Given this list of marker genes ATG101, FTCD, QKI (QKI, KH domain containing RNA binding), CES1, TRIO, DCAKD, MUC13, MMS19, OXCT1, FGF5, B2M (beta-2-microglobulin), GPR17, RAB29, CTNNA2, GNPTAB, PSMB8, APEH, CRIP3, PSME1, IFIT2, TRIM68, HTATIP2, KRTAP4-11, EMC3 (ER membrane protein complex subunit 3), RANBP9, E2F7, TMEM268, FYB1, LIPA, CNN3, LAMP2, RAI2, KCTD18 (potassium channel tetramerization domain containing 18), MINAR1, CAP1, ZDHHC6, CSTF2T, TMEM217, CHADL, RDH14 (NCBI Gene Id 57665), ITM2B, LRRC72, SPX, GDAP1, KLHL41, ZFAND3, ARID3B, CHRNA1, TRAF2 (NCBI Gene Id 7186), KAZALD1, VPS4B (NCBI Gene Id 9525), RBKS, TXLNA, KNSTRN, LARP6, MINAR2, C2CD4C, LPIN2, EBPL, G6PD, CD300LG, NPAT, CIB1, SP110, CENPU, IL9R, CLASP1, RND1, STRC, SUSD6, HLA-G, CPD, ZNF335, MED8, YIPF1, FUNDC1, MPI, TWF1, WASHC2A, GNG2, PARD6G, LDHC, GTF3C5, RFXANK, DNAJC5, SLC2A1, GSDMD, DYDC2, USF1, DIAPH3, MED29, NID1, SUCO, MYT1L, SYCP2L, CCDC77, GPCPD1, MCUB, SYNE2, PPHLN1, PGD, PLA2G15, URGCP, SBDS, CFHR2, KDM5C, FAM83D, ODAD3, MAST2, GABRG1, PHRF1, TAOK1, ATOSA, CYB5R3, COL4A5, HMGCS1, CD247, SFRP1, IPO8, TRAM2, DENND10, ARHGEF3, SNAI3-AS1 (SNAI3 antisense RNA 1), TRAM1L1, NCAPG, CAP2, TMEM140, KIF20A, IFNAR2, ASCL1, NAA50, ATG3, ADAM9, MSX2, FBXO24, PTPRR (NCBI Gene Id 5801), NTN5, NDC80, GSTT1, CDK5RAP3, LEO1, GNG8, GDPGP1, CDCA3, SLC30A9, SOCS7, MFN1, SLC9A9, PON3, NDUFS3, OSMR, GTF3C2, SLAMF1, MBOAT2, SHCBP1, MAT2A, ERBB4, CLASRP, RUNDC1 (RUN domain containing 1), MTUS1, KIF18B, RIOK1, BRCA2, PSMD4, MFSD8, TMEM181 (NCBI Gene Id 57583), ALPK3, HTR3B, TMEM87A, DCUN1D2, COG3, CYB5R2, SLC35F3, SULT4A1, FANCD2, ARL15, KPNA7, SYT3, NPY2R, PUS7L, CARS2, TINF2, CHD1L, ECI2, GGH, CASP6, SPAG9, PSME4, EPRS1 (NCBI Gene Id 2058), PPP3CC, VAPB, KNL1, OPA1, PTP4A2, DNAJB13, PRR11, KBTBD2, BLMH, VIPAS39, MAPK7, here is a description of the gene set: Borrelia burgdorferi, the agent of Lyme disease, promotes pro-inflammatory changes in endothelium that lead to the recruitment of leukocytes. The host immune response to infection results in increased levels of IFN-gamma in the serum and lesions of Lyme disease patients that correlate with greater severity of disease. Therefore, the effect of IFN-gamma on the gene expression profile of primary human endothelial cells exposed to B. burgdorferi was determined. B. burgdorferi and IFN-gamma synergistically augmented the expression of genes, seven of which encode chemokines. Six of these (CCL7, CCL8, CX3CL1, CXCL9, CXCL10, and CXCL11) attract T lymphocytes, and one (CXCL2) is specific for neutrophils. Synergistic production of the attractants for T cells was confirmed at the protein level. IL-1beta, TNF-alpha, and LPS also cooperated with IFN-gamma to induce synergistic production of CXCL10 by endothelium, indicating that IFN-gamma potentiates inflammation in concert with a variety of mediators. An in vitro model of the blood vessel wall revealed that an increased number of human T lymphocytes traversed endothelium exposed to B. burgdorferi and IFN-gamma, as compared to unstimulated endothelial monolayers. In contrast, addition of IFN-gamma diminished the migration of neutrophils across B. burgdorferi-activated endothelium. IFN-gamma thus alters gene expression by endothelium exposed to B. burgdorferi in a manner that promotes recruitment of T cells and suppresses that of neutrophils. This modulation may facilitate the development of chronic inflammatory lesions in Lyme disease. from publication Dame TM, Orenzoff BL, Palmer LE, Furie MB (PMID 17202382) Human Gene Set: GSE6092_UNSTIM_VS_IFNG_STIM_AND_B_BURGDORFERI_INF_ENDOTHELIAL_CELL_UP Genes up-regulated in endothelial cells: untreated versus IFNG and B. burgdoferi. species: Homo sapiens